Given this list of marker genes Ube2s, Kif2b, Psmd13, H4c8, H2bc8, Tubb6, Psmc5, Nedd1, H2bc27, Gorasp1, H2bc3, Cenpu, Anapc10, Haus8, Tubgcp3, H4c18, Ppp2r1b, Psma3, Emd, H4c9, Psma5, Ubb, Ran, Cdc26, Aurkb, H4c1, Tuba4a, Vrk1, Psmc4, Cep152, H2ac13, Kif20a, Ppp2r5b, Sfi1, Rps27a, Rad21, Clasp1, Kif2c, Kntc1, Anapc7, Psmb7, Ndc80, Tubb2b, Cep131, Smc3, Actr1a, H2ac10, Sdccag8, Ppp2r5d, H3c4, B9d2, Nudc, Seh1l, Tuba1a, Ninl, Itgb3bp, Cep192, Lmna, Ccnb1, H2bc13, Psmc6, Prkar2b, H2bc22, H3c2, Xpo1, Psmd6, Nup210, Ncapg2, H2bc7, Psma1, Dctn1 (NCBI Gene Id 13191), Haus5, Psmb4, Ndel1, Cc2d1b, H2ac1, Nup93, Ska1, H2ac4, Aaas, Psmb5, Psmc3, Ist1, H3c10 (NCBI Gene Id 319152), H4c6 (NCBI Gene Id 319157), Firrm, Psmc1, Sumo1, Cenpt, Psma7, H4c3, H2ac22, Cenpq, Mad1l1, Ube2d1, H2ac23, Rab1b, Psmd7, Mapk3 (NCBI Gene Id 26417), Ube2e1, H2ac6 (NCBI Gene Id 319164), H2ac20, Nup133, H2bc15, Chmp2a, H3c6, Ppp2r2a, Tuba1c, Cep57, H2ac7, Lbr, Dynll1, Anapc15, Plk1, Cdk1, H3c8, Kpnb1 (karyopherin subunit beta 1), H2ac12, H4c11, Eml4, H3c3, Chmp2b, Tuba1b, Psmd1, Cenpn, Mzt1, H2ac19, Cep41, Anapc2, Nup85, Ankle2, Mad2l1, Zwilch (zwilch kinetochore protein), Prkaca, Rae1, Tubgcp6 (tubulin, gamma complex component 6), Psmd12, Nup42, Stag1 (STAG1 cohesin complex component), H4c12, Psmc2, Spc24, H2ac11 (H2A clustered histone 11), H4c4, Nup155, Hdac8, Tuba8, H3f3a, Tuba3b, Csnk2b, H3c15, Cep135, Nde1, H2bc1, Tubal3, Cenps, H2ac15, Cep290, Cenpm, Cep43, Cenpe, Psmb6, Ctdnep1, H3c1, H2ac24, Nup58, Cep72, Dync1li2, Ywhae, H2az2, Tubb4a, Tubgcp2, Cenpa, H3c11, Nup205, Ppp2r5a, Nup54 (NCBI Gene Id 269113), Vrk2, H3c7, Rb1, Ndc1, H4c14, Ncaph, Psma4, H2ac8, Cenpj, H3c13, Ube2c, H4c17, Psma6, H4c2, H2bc9, Cep63, Cdc23, Haus1, Psma2, Mis12, H2ax, H2bc11, Tubb4b, H2bc12, Ncapd3, Golga2, Lmnb1, Blzf1, Rab1a, Prkca, Haus7, Csnk1e, here is a description of the gene set: electronically inferred by orthology from the curated human pathway This event has been computationally inferred from an event that has been demonstrated in another species.<p>The inference is based on the homology mapping from PANTHER. Briefly, reactions for which all involved PhysicalEntities (in input, output and catalyst) have a mapped orthologue/paralogue (for complexes at least 75% of components must have a mapping) are inferred to the other species. Reactome Pathway: M Phase species: Mus musculus part of: Cell Cycle, Mitotic